Given this list of marker genes HLA-DPA1, HLA-DMB (major histocompatibility complex, class II, DM beta), HLA-DRB4, HLA-DRA, HLA-DQA1, HLA-DOA, HLA-DPB1, HLA-DQB1, HLA-DMA, HLA-DOB, HLA-DRB3, NFYB, HLA-DRB5, HLA-DRB1, HLA-DQA2, here is a description of the gene set: studied in species Homo sapiens Human Gene Set: KEGG_MEDICUS_PATHOGEN_HTLV_1_TAX_TO_NFY_MEDIATED_TRANSCRIPTION Pathway Definition from KEGG: TAX -> NFYB => MHCII HTLV-1 Tax to NFY-mediated transcription. Pathway ID: N00508. Pathway type: Pathogen. Pathway class: nt06160 Human T-cell leukemia virus 1 (HTLV-1).